Given this list of marker genes ADCY3, LMX1A, CHD7, SHANK1, BBS1, UBR3, WFS1, ATP6V1B1, GJB4, CFAP69, TPBG, here is a description of the gene set: species: Homo sapiens Human Gene Set: GOBP_OLFACTORY_BEHAVIOR The behavior of an organism in response to an odor.